The following is a description of a gene set: Human Gene Set: CCAWNWWNNNGGC_UNKNOWN Comprehensive identification of all functional elements encoded in the human genome is a fundamental need in biomedical research. Here, we present a comparative analysis of the human, mouse, rat and dog genomes to create a systematic catalogue of common regulatory motifs in promoters and 3' untranslated regions (3' UTRs). The promoter analysis yields 174 candidate motifs, including most previously known transcription-factor binding sites and 105 new motifs. The 3'-UTR analysis yields 106 motifs likely to be involved in post-transcriptional regulation. Nearly one-half are associated with microRNAs (miRNAs), leading to the discovery of many new miRNA genes and their likely target genes. Our results suggest that previous estimates of the number of human miRNA genes were low, and that miRNAs regulate at least 20% of human genes. The overall results provide a systematic view of gene regulation in the human, which will be refined as additional mammalian genomes become available. from publication Xie X, Lu J, Kulbokas EJ, Golub TR, Mootha V, Lindblad-Toh K, Lander ES, Kellis M (PMID 15735639) Genes having at least one occurrence of the highly conserved motif M165 CCAWNWWNNNGGC in the regions spanning 4 kb centered on their transcription starting sites. The motif does not match any known transcription factor binding site. species: Homo sapiens, and this is the list of marker genes: AZIN1, RPL18A, HOXA10, POLD4, B3GNT5, FEZF2, ENTPD3, ARCN1, ATRX, CCNE1, YBX3, ARIH1, OTX2, BCL2L13, RBM26, EMX2, MAP1A, ADK, ZCWPW1, MEPCE, FIZ1, CSDE1, ZBTB47, ZC3HC1, DMD, RBM39, NKX6-3, ATP5MC2, BPIFB2, UBE3A, AP1G1, EIF1B, DRAM2 (DNA damage regulated autophagy modulator 2), HDAC6, TLX3, ROBO1, FAM193B, HMGXB4, SMYD5 (SMYD family member 5), BSPRY, HNRNPA0, ZNF326 (NCBI Gene Id 64842), NUDT3, CNOT3, ZWILCH, UBE2K, SNX13, RAB22A, DAP3, H3C8, HOXC4, ZFY, PCGF1, CELF1, FERMT2, INO80D, FKRP, TSC1, ZNF524, CDC42BPB, STRN4, HOXC6, ABL1, ABRAXAS2, RIF1, MED13, KRT8P41, ZFX, HEXIM2, TRIM8, ADNP, YY1AP1 (NCBI Gene Id 55249), RPL4, IRF9, VEGFA, SAT1 (NCBI Gene Id 6303), COL1A1, RABL6, PPP2R5E, LSM14A, CAMSAP1, STAG1, CDKN2C, H2BC10, CNKSR2, SALL1, CABP1